The following is a description of a gene set: studied in species Mus musculus The covalent attachment of a palmitoyl group to a protein. Mouse Gene Set: GOBP_PROTEIN_PALMITOYLATION, and this is the list of marker genes: Zdhhc6, Hhatl, Zdhhc11, Zdhhc15, Zdhhc20, Zdhhc12, Zdhhc19, Zdhhc16, Zdhhc18, Zdhhc22 (NCBI Gene Id 632803), Zdhhc8, Golga7, Clip3, Zdhhc3 (NCBI Gene Id 78884), Map6d1, Zdhhc21, Zdhhc23, Zdhhc17, Selenok, Zdhhc5, Zdhhc7, Zdhhc1, Zdhhc14, Hhat, Glul, Zdhhc2, Zdhhc9